Given this list of marker genes Irf1, Nos2, Cxcl10, Icam1, Cybb, Cxcl9, Irf4, Jak1, Irf8, Prkcd, Ifit2, Eif2ak2, Il1b, Irf2, Spi1, Socs3, Irf9, H4c14, Isg15, Ifngr2, Ifngr1, Ifnb1, Ciita (class II transactivator, NCBI Gene Id 669998), Jak2 (NCBI Gene Id 98155), Stat2, Psmb9, Tap1, Stat1, Ifng, Socs1, Ptpn11, Gbp2b, here is a description of the gene set: Mouse Gene Set: WP_TYPE_II_INTERFERON_SIGNALING_IFNG Type II interferon signaling (IFNG) species: Mus musculus